Given this list of marker genes Cela1, Ctsl, Lep, Cst3, Mmp12, Hif1a, here is a description of the gene set: The chemical reactions and pathways involving elastin, a glycoprotein which is randomly coiled and crosslinked to form elastic fibers that are found in connective tissue. studied in species Mus musculus Mouse Gene Set: GOBP_ELASTIN_METABOLIC_PROCESS